Given this list of marker genes FAM8A1 (NCBI Gene Id 51439), HERPUD1, MARCHF6, ELOB, USP33, SYVN1, RBX1, UBE2J1, SEL1L, OS9, here is a description of the gene set: A ubiquitin ligase complex found in the cytoplasm. Human Gene Set: GOCC_CYTOPLASMIC_UBIQUITIN_LIGASE_COMPLEX studied in species Homo sapiens